Given this list of marker genes DNAI7, H2AJ, CAPZA3, LRRC23, CLEC12B, PLCZ1, AKAP3, SOX5, GSG1, ACRBP, RASSF8, here is a description of the gene set: Human Gene Set: KORKOLA_CHORIOCARCINOMA_DN species: Homo sapiens Genes from the 12p region that were down-regulated in choriocarcinoma cells compared to normal testis. from publication Korkola JE, Houldsworth J, Chadalavada RS, Olshen AB, Dobrzynski D, Reuter VE, Bosl GJ, Chaganti RS (PMID 16424014) Adult male germ cell tumors (GCTs) comprise distinct groups: seminomas and nonseminomas, which include pluripotent embryonal carcinomas as well as other histologic subtypes exhibiting various stages of differentiation. Almost all GCTs show 12p gain, but the target genes have not been clearly defined. To identify 12p target genes, we examined Affymetrix (Santa Clara, CA) U133A+B microarray ( approximately 83% coverage of 12p genes) expression profiles of 17 seminomas, 84 nonseminoma GCTs, and 5 normal testis samples. Seventy-three genes on 12p were significantly overexpressed, including GLUT3 and REA (overexpressed in all GCTs) and CCND2 and FLJ22028 (overexpressed in all GCTs, except choriocarcinomas). We characterized a 200-kb gene cluster at 12p13.31 that exhibited coordinated overexpression in embryonal carcinomas and seminomas, which included the known stem cell genes NANOG, STELLA, and GDF3 and two previously uncharacterized genes. A search for other coordinately regulated genomic clusters of stem cell genes did not reveal any genomic regions similar to that at 12p13.31. Comparison of embryonal carcinoma with seminomas revealed relative overexpression of several stem cell-associated genes in embryonal carcinoma, including several core stemness genes (EBAF, TDGF1, and SOX2) and several downstream targets of WNT, NODAL, and FGF signaling (FGF4, NODAL, and ZFP42). Our results indicate that 12p gain is a functionally relevant change leading to activation of proliferation and reestablishment/maintenance of stem cell function through activation of key stem cell genes. Furthermore, the differential expression of core stem cell genes may explain the differences in pluripotency between embryonal carcinomas and seminomas.